Given this list of marker genes Entpd3, Entpd8, Entpd7 (ectonucleoside triphosphate diphosphohydrolase 7), Entpd5, Entpd2, here is a description of the gene set: electronically inferred by orthology from the curated human pathway studied in species Mus musculus Reactome Pathway: Phosphate bond hydrolysis by NTPDase proteins part of: Nucleotide catabolism This event has been computationally inferred from an event that has been demonstrated in another species.<p>The inference is based on the homology mapping from PANTHER. Briefly, reactions for which all involved PhysicalEntities (in input, output and catalyst) have a mapped orthologue/paralogue (for complexes at least 75% of components must have a mapping) are inferred to the other species.